Given this list of marker genes H4C3, H2AX, ASPM, BIRC5, CENPM, MAD2L1, KIF22, KPNA2, UBE2T (ubiquitin conjugating enzyme E2 T), PCNA, TUBA1B, ANP32E, SMC4, RRM2, PTTG1, DUT, NUSAP1, TUBB4B, CKS2, HMGN2, CKAP2, KIF20B, HMGB2, H2AZ1, CENPW, UBE2C, MCM7, CDKN3, PCLAF, TMPO, TUBA1C, CENPF, STMN1, CKS1B, MKI67, ZWINT, DTYMK, SMC2, SKA2, PRC1, GGH, RPA3, UBE2S, TYMS, TOP2A, TUBB, TK1, TMEM106C, CLSPN, CDK1, here is a description of the gene set: studied in species Homo sapiens Genes upregulated in subsets of cells of a given type within various tumors Human Gene Set: GAVISH_3CA_METAPROGRAM_ENDOTHELIAL_CELL_CYCLE In this study, an extensive analysis was conducted to define meta-programs (MPs) capturing intra-tumor heterogeneity across a spectrum of tumor types. The approach utilized non-negative matrix factorization (NMF) to analyze each cell type separately within individual tumor samples. This involved the analysis of malignant cells, macrophages, fibroblasts, endothelial cells, epithelial cells, T-cells, and B-cells. NMF was executed with varying parameter values (K=4, 5, 6, 7, 8, 9), thereby generating 39 programs for each cell type per sample. Each NMF program was summarized by the top genes based on NMF coefficients.\nRobust MPs were then delineated for each cell type using a set of stringent criteria, including recurrence within the same tumor, similarity to programs in other tumors, and non-redundancy within a tumor. Subsequently, these robust NMF programs were clustered (per cell type) based on Jaccard similarity, leading to the identification of MPs associated with each cell type.\nTo enhance the quality of the MPs, a refinement steps were undertaken, involving the removal of MPs suspected of reflecting low-quality data (with an overrepresentation of ribosomal proteins or mitochondrial-encoded genes), single-study inclusion, or similarity to miss-annotated cell types. from publication Gavish A, Tyler M, Greenwald AC, Hoefflin R, Simkin D, Tschernichovsky R, Galili Darnell N, Somech E, Barbolin C, Antman T, Kovarsky D, Barrett T, Gonzalez Castro LN, Halder D, Chanoch-Myers R, Laffy J, Mints M, Wider A, Tal R, Spitzer A, Hara T, Raitses-Gurevich M, Stossel C, Golan T, Tirosh A, Suvà ML, Puram SV, Tirosh I (PMID 37258682)